The following is a description of a gene set: species: Mus musculus Mouse Gene Set: GOMF_P53_BINDING Binding to one of the p53 family of proteins., and this is the list of marker genes: Pou4f2, Rchy1, Rffl, Nuak1, Smarca4, Ehmt1, Prmt5, Blm, Htt, Taf9, Sirt1, Eef2, Zfp385a (zinc finger protein 385A), Gata1, Ankrd1, Ntrk3, Trp53bp2, Msx1 (NCBI Gene Id 269644), Trp73, Trp63, Rnf125, Daxx, Mapkapk5, Hspd1, Trp53rkb, Brca1, Rfwd3, Setd7, Brd4, Zfp385b, Hdac1, Hif1a, Chd8, Mul1, Tep1, Crebbp, Dazap2, Axin1, Kdm1a, Ptges3, Pttg1ip, Triap1, Ppp1r13b, Taf1, Mdm2, Ehmt2, Cdkn2aip, Smyd2, Cdkn2a, Ybx1, Ep300, Usp10, Cdk5, Kdm8, Brd7, Noc2l, Trim29, Stk11, Usp7, Trim24, Smarcb1, Bcl2l12, Muc1, Gsk3b, Npm1, Nop53, Dusp26, Trp53rka, Armc10, Trp53, Trp53bp1, Plk3, Taf3, Rnf34, Rnf20, Psme3